The following is a description of a gene set: Analysis of the transcriptional response to SARS-CoV-2 compared with other respiratory viruses, including MERS-CoV, SARS-CoV-1 (SARS), human parainfluenza virus 3 (HPIV3), respiratory syncytial virus (RSV), and IAV. from publication Blanco-Melo D, Nilsson-Payant BE, Liu WC, Uhl S, Hoagland D, Møller R, Jordan TX, Oishi K, Panis M, Sachs D, Wang TT, Schwartz RE, Lim JK, Albrecht RA, tenOever BR (PMID 32416070) Genes up-regulated oninfection of normal human bronchial epithelial cells by Influenza A (MOI: 3, 12hpi) Human Gene Set: BLANCO_MELO_BRONCHIAL_EPITHELIAL_CELLS_INFLUENZA_A_INFECTION_UP studied in species Homo sapiens, and this is the list of marker genes: ZNF674-AS1, DHX58, ZBTB21, TLN2, IFI35, SHISAL1, NR1D1, ZNF441, CD83, TMEM47, SMG1P1, LIFR, H2BC8, SLC5A3, GTF3C4, TRIM25, BATF2, TAP1, ATP5F1E, ZPLD1, IPO11, DDIT3, ZBED6, CLDN16, ERN1, HERC5, THBS1, NOMO3, PWWP3B, MAN2A1, XIST, RALGAPA2, HLA-F, IGF2R, NBEAL1, SLC30A1, IL7R, SLFN5, EGFR (NCBI Gene Id 1956), OLFM2, TNFAIP3, BIRC3, ZNFX1, NR1D2, ARRDC3, MAFB, EDIL3, UGDH, ZNF736, TTBK2, TNF, VWA7, PLAT, TMEM140, RGS16, ASXL2, CSF1, ROCK2, ULBP1, ZNF551 (NCBI Gene Id 90233), NOMO2, ZKSCAN8, UBXN7, SAMHD1, IL6, PTX3, BICC1 (BicC family RNA binding protein 1), SEL1L, CCL5, NLRC5, SIRPB1, KIF17, PTGS1 (prostaglandin-endoperoxide synthase 1), COL6A1, XAF1, GBP1, ZNF699, MAN1A2, ETV3, DDI2, EPSTI1, ZNF844, CXCL10, HSPA6, TRAF1, MED13, LNPEP, SDK1, ZNF778, RESF1, MIB1, ID2, ITGAV, ITPR1, ITGA7, BEND3P3, TRANK1, POSTN, RNASE7, IRF9, PYGM, FSD1L, C1S, SERPINB10, NIPAL1, MACF1, ZBTB10, EXOC6B, AOC2, KBTBD8, HEPHL1, HERC6, CD109 (NCBI Gene Id 135228), EIF2AK2, PARP9, LIMCH1, SPMIP1, LINC01089, WFDC2, ICAM1, GULP1, CDYL2, HELZ2, DPP4, CRYBG3, SERPINB4, HACD2, ARL5B, SEC24A, CXCL11, ZKSCAN1, DTX3L, TFRC, MAPK8IP2, USP18, RAD54L2, NEU3 (NCBI Gene Id 10825)